The following is a description of a gene set: Reactome Pathway: Kidney development Kidney development begins at embryonic day 8.5 (E8.5) in mouse embryos, a time after gastrulation and formation of the intermediate mesoderm. Renal progenitors are specified within the intermediate mesoderm in the region between the 6th and 8th somites. The nephric duct then begins to form by mesenchymal to epithelial transitions of the renal progenitors and grows caudally to fuse with the bladder and urethra primordium (cloaca). The nephric duct induces the formation of mesonephric tubules in the adjacent nephric cord which form the mesonephros, an embryonic kidney in mammals that regresses and is supplanted by the metanephros. (In anamniotes such as frogs and fish, the mesonephros is the adult kidney and no metanephros forms.) <br>In mammals, the metanephros is initiated as the caudal region of the nephric cord forms metanephric mesenchyme which then interacts with the nephric duct to induce formation of the ureteric bud, the progenitor of the ureter. Branching of the ureteric bud forms ureter tips which induce nephron formation in the surrounding metanephric mesenchyme. <br>Induction of kidney development in the intermediate mesoderm occurs by incompletely characterized signals from the adjacent ectoderm and lateral plate mesoderm. Notably, BMP activity from the lateral plate mesoderm can induce expression of the renal markers Pax2 and Lhx1.<br>Foxc1 and Foxc2 expressed in the paraxial mesoderm repress Lhx1 and prevent over-expansion of the intermediate mesoderm. Conversely, Nodal signaling maintains Pax2 expression and prevents over-expansion of the paraxial mesoderm. The rostral-caudal position of renal development appears to specified by the rostral-caudal gradient of retinoic acid acting through HoxB4 (Preger-Ben Noon et al. 2009) and limited caudally by HoxA6. <br>The combined expression of Pax2, Pax8, Lhx1, and Gata3 is the earliest observed marker of the renal lineage and these transcription factors, together with Emx2, form a self-reinforcing module that drives formation of the nephric duct. Nephronectin (Npnt) from the nephric duct interacts with integrin alpha8/beta1 (Itga8) on the metanephric mesenchyme and Ret located on the nephric duct interacts with Gdnf secreted by the metanephric mesenchyme to regulate formation and branching of the ureteric bud. Signals from the tips of the ureteric bud then induce epithelialization of the metanephric mesenchyme and formation of nephrons, the basic filtration units of the kidney comprising the glomerulus, the proximal tubule, the loop of Henle, and the distal tubule. Canonical Wnt signaling from the ureteric bud appears to be the main inductive event: Wnt9b activates Wnt4 expression to epithelialize mesenchymal pre-tubular aggregates and Wnt9b also supports expression of Six2 to maintain a nephron progenitor pool in the cap mesenchyme.<br>Congenital anomalies of the kidney and urinary tract (CAKUT) comprise about 30% of antnatal congenital abnormalities and cause the majority of chronic kidney disease in children. Knowledge gained from studying kidney development is being used to generate kidney organoids in vitro with a goal of producing transplantable kidney tissue. studied in species Homo sapiens part of: Developmental Biology, and this is the list of marker genes: FGF2, IRX1, HNF4A, HNF1B, WFDC2 (WAP four-disulfide core domain 2), POU3F3, WNT11, GREM1, PCDH19, WNT4, BMP4, SLIT2, HOXB4, EYA1, CTNNB1 (NCBI Gene Id 1499), SIX1, GATA3, SIX2 (SIX homeobox 2), HOXD11, PAX8, PLAC8, FOXC1, NPNT, ROBO2, GFRA1, ID4, EMX2, IRX2, HOXA11, FOXC2, JAG1, MECOM, GDNF, HOXA6, PAX2, ITGB1, RET, HOXC11, LFNG, OSR1, WNT9B, WT1, SALL1, DLL1, LHX1, ITGA8